The following is a description of a gene set: Human Gene Set: JOHNSTONE_PARVB_TARGETS_2_UP species: Homo sapiens Parvin-beta is a focal adhesion protein downregulated in human breast cancer cells. Loss of Parvin-beta contributes to increased integrin-linked kinase activity, cell-matrix adhesion, and invasion through the extracellular matrix in vitro. The effect of ectopic Parvin-beta expression on the transcriptional profile of MDA-MB-231 breast cancer cells, which normally do not express Parvin-beta, was evaluated. Particular emphasis was placed upon propagating MDA-MB-231 breast cancer cells in three-dimensional culture matrices. Interestingly, Parvin-beta reexpression in MDA-MB-231 cells increased the mRNA expression, serine 82 phosphorylation (mediated by CDK9), and activity of the nuclear hormone receptor peroxisome proliferator-activated receptor gamma (PPARgamma), and there was a concomitant increase in lipogenic gene expression as a downstream effector of PPARgamma. Importantly, Parvin-beta suppressed breast cancer growth in vivo, with associated decreased proliferation. These data suggest that Parvin-beta might influence breast cancer progression. Genes up-regulated upon overexpression of PARVB in MDA-MB-231 cells (breast cancer) cultured in 3D collagen I and 3D Matrigel only. from publication Johnstone CN, Mongroo PS, Rich AS, Schupp M, Bowser MJ, Delemos AS, Tobias JW, Liu Y, Hannigan GE, Rustgi AK (PMID 17998334), and this is the list of marker genes: DMPK, RAB29, SERPINE1, TFE3, MT-ND4, FASN (NCBI Gene Id 2194), IGFBP6, FURIN, EEF1A2, ALDH1A3, CALR, WBP2, B2M, TP53, ERGIC3 (NCBI Gene Id 51614), S100A11, GFOD1, CXCR4, FST, YWHAE (NCBI Gene Id 7531), TFPI2, BASP1, TNFAIP3, DLGAP4, SCAMP4, RPL5 (NCBI Gene Id 90045), TGFB1, EMB, PPP1R9B, DBNDD2, KRT8, BRD9, CORO1B, AIF1L, SLC25A1, KCTD13, PTPA, AGPAT2, SBNO2, MT-ND5, HLA-DRB1, UAP1L1, H1-0, DDX60, NCOA7, CD151, HLA-B, TRAPPC1, IFIT1, GATA6 (NCBI Gene Id 2627), LY6E, FKBP1A, RPL36A, PLEK2, IGFBP4, SPTAN1, AKR1C1, IRX3, MDK, IFI27, EEF1A1, UBE2L6, CITED2, KRT18, PLAAT4, OTUB1, ACTB, RAB11B, ARHGDIA, MINK1, BSG, BCL2L1 (NCBI Gene Id 598), CFL1 (cofilin 1), MOAP1, CLPTM1L, SMAD3, RAMP1, HGS (hepatocyte growth factor-regulated tyrosine kinase substrate), ZYX, OAF, APLP2, ISG15, OASL, HLA-A, GALC, VEGFB, CMTM6, LSR, ASXL2, USP11, TPT1, EREG, GREB1, TXNRD1, FXYD5, CLPTM1 (NCBI Gene Id 1209), LYSMD2, MAMDC2 (NCBI Gene Id 256691), GNAI2, CD74, PLAT, GPR137, PKN1, STXBP2, WWC1, ACTG1, COTL1, VSIR, MT-ATP6, TNIK, PKM, SNAP29, CSF2RA, GSTM3, GPRC5A, CALM3, G6PD, ECM1, NECTIN2, TPP1 (tripeptidyl peptidase 1), MT-CO1, FLNA, GALNT6, IFIT3, CAVIN1, AKR1B1, EPHX1, HLA-DPA1, UBE2V1, GRAMD1B, NDUFB1, PCOLCE2, IFIT2, HEG1, CCRL2, TLN1, OGDH, IFITM1, SEL1L3, GRINA, SLC4A2, ZNFX1, NSMF